Given this list of marker genes APOE, PCSK9, APOB, ABCG8, ABCG5, PCK1, LDLR, LDLRAP1, EYA1, PCK2, SIX1, here is a description of the gene set: Abnormal fat accumulation in the kidneys. species: Homo sapiens Human Gene Set: HP_RENAL_STEATOSIS Renal steatosis